The following is a description of a gene set: Any process that activates or increases the frequency, rate or extent of T-helper 17 cell lineage commitment. Mouse Gene Set: GOBP_POSITIVE_REGULATION_OF_T_HELPER_17_CELL_LINEAGE_COMMITMENT species: Mus musculus, and this is the list of marker genes: Opa1, Ep300, Brd2, Brd4, Il23a